Given this list of marker genes POLD1, RPS20, SMAD4, KRAS, BRCA2, EPCAM, TGFBR2, CDKN2A, CDC73, RNF43, POLE, PIK3CA (phosphatidylinositol-4,5-bisphosphate 3-kinase catalytic subunit alpha), MUTYH, PALLD, ATM, BMPR1A, SPINK1, MLH1, MSH2, SEMA4A, RABL3, PMS1, COL14A1, PMS2, PALB2 (NCBI Gene Id 79728), CHEK2, MSH6, TP53, BRCA1, CTRC, NTHL1, AAGAB, STK11, here is a description of the gene set: Pancreatic adenocarcinoma Human Gene Set: HP_PANCREATIC_ADENOCARCINOMA The presence of an adenocarcinoma of the pancreas. studied in species Homo sapiens